Given this list of marker genes CAPN5, POU3F4, CFI, EFEMP1, APC, CFH, MUTYH, here is a description of the gene set: Human Gene Set: HP_HYPERPIGMENTATION_OF_THE_FUNDUS species: Homo sapiens Hyperpigmentation of the fundus Increased pigmentation of the fundus